Given this list of marker genes Gcat, Gldc, Glyat, Gcsh, Shmt2, Gnmt (glycine N-methyltransferase), Tdh, Ndp, Shmt1, Baat, Phgdh, Amt, Agxt, Tha1, Agxt2, Hao1, Gart, here is a description of the gene set: species: Mus musculus The chemical reactions and pathways involving glycine, aminoethanoic acid. Mouse Gene Set: GOBP_GLYCINE_METABOLIC_PROCESS